Given this list of marker genes Ift20, Phf14, Adipoq, Cblb, Cbl, here is a description of the gene set: studied in species Mus musculus Any process that modulates the frequency, rate or extent of platelet-derived growth factor receptor-alpha signaling pathway. Mouse Gene Set: GOBP_REGULATION_OF_PLATELET_DERIVED_GROWTH_FACTOR_RECEPTOR_ALPHA_SIGNALING_PATHWAY